The following is a description of a gene set: Human Gene Set: GOBP_RESPONSE_TO_MINERALOCORTICOID studied in species Homo sapiens Any process that results in a change in state or activity of a cell or an organism (in terms of movement, secretion, enzyme production, gene expression, etc.) as a result of a mineralocorticoid stimulus. Mineralocorticoids are hormonal C21 corticosteroids synthesized from cholesterol and characterized by their similarity to aldosterone. Mineralocorticoids act primarily on water and electrolyte balance., and this is the list of marker genes: CRH, AANAT, PTPRC, CARD9, CSN1S1, NTRK3, SLC12A3, UCN3, PARP1, CYBB, PRKCA, EDN1, AIFM1, SH3RF1, CYBA, HCN2, SCNN1A, FOSB, SCNN1D, CCND1, COMT, GPER1, FOS, KRAS, AVPR1A, SCNN1B, STK39, INHBA, SCNN1G, SGK1, NEFL, HDAC6, CALM3, FOXO3, PRKN, RAN, NPAS4